Given this list of marker genes SIRT1, PNPLA3, RETREG1, NPR2, PPARG, ADIG, ATF2, PER2 (NCBI Gene Id 8864), FAM83A, CTBP1, TBL1XR1, FABP4, ID2, SNAI2, CTBP2, PDGFRA, FGF10, FFAR4, CEBPA, here is a description of the gene set: The process in which a relatively unspecialized cell acquires specialized features of a white adipocyte, an animal connective tissue cell involved in energy storage. White adipocytes have cytoplasmic lipids arranged in a unique vacuole. species: Homo sapiens Human Gene Set: GOBP_WHITE_FAT_CELL_DIFFERENTIATION